Given this list of marker genes Erg, Neo1, Nedd4l, Ubr5, Gria3, Dlx1, Cul1, Tmem185a, Faxc, Dnmt3a, Homer1, Eif4enif1, Usp47, Slc24a2, Arhgef3, Nr3c1, Dab2ip, Ist1, Tnfsf11, Nfkbiz, Pes1, Magi2, Rab14, Txndc16, Daam1, Kpna4, Ap4m1 (adaptor-related protein complex AP-4, mu 1), Wtap, Gorasp2, Lmx1a, Usp31, Pdzrn4, Crispld1, Dcun1d1, Trp53inp1, Phf8, Kcnk1, Nxph2, Ctdspl2, Rc3h2, Ndrg4, Zic2, Ccdc82, Atl2, Tdo2, Cdh11, Vwc2l, Map4k3, Mllt10, Phactr1, Dynll1, Cntn1, Tanc2 (NCBI Gene Id 77097), Fmr1, Rora, Sdc3, Bfar, Rfx4, Slain2, Trhde, Slc35a3, Stag1, Ccdc83, Sp3, Brd10 (bromodomain containing 10), Slc20a2, Cyp4b1, Mbnl2, Msh3, Rreb1, Brca1, Sufu, Sema3e, Vav2, Arfgef1, Tab2, Col8a1, Dync2i1, Usp1, Nus1, Bcl6, Crebzf, App, Ppargc1a, Rin2, Fst, Lypla1, Tsc22d2, Gng5, Kmt2e, Esco2, Nfkbia, Nadk2, Vezf1, Satb1, Gtf2ird1, Ppp6r3, Bbc3, Kif21b, Abcc5, Sat1, Med13l, Vldlr, Nckap5, Gmps, Tlk1, Rab5c, Vps13d, Krtap13, Syt4, Osbpl1a, Fli1, Slc25a24, Tal1, B3gnt9, Rai1, Thap11, Psma5, Arhgef10l, Flrt3, Gas6, Xkrx, Tbc1d22b, Nek7, Scamp5, P2ry12, Dach1, Megf11, Hmgb2, Vangl2, Akap11, Tenm3, Npat, Hid1, Hmcn1, Rbm27 (RNA binding motif protein 27), Slc22a2, Senp7, Mrfap1, Shisa6, Dctn2, Elovl5, Dlc1, Lingo1, Susd6, Tbp, Hhip, Lhfpl3, Mbd5, Ccng2, Nid1, C1qbp, Areg, Fam228a, Myt1l, Arid4b, Stxbp5l, Slitrk6, Pom121, Anp32b, Lgr5, Zfp367, Naa15, Gon4l, Birc6 (baculoviral IAP repeat-containing 6), Mycbp2, Psmg2, Gtf2a1, Son, Iqub, Chrd, Rock1, Fezf2 (Fez family zinc finger 2), Klf15, Bcl11b, Atp13a3, Ebf3, Gabra5, Cxxc4, Itgb1, Kmt2d, Slc25a12, Arl8a, Mea1, Map3k8, Itga10, Zfp442, Arhgap44, Dennd4c, Myo1e, Gak, Zfp638, Fubp1, Hmgn1, Lrig1, Derl1, Snrpb2, Cited2, Ash1l, Cimip2a, Gramd4, Agps, Anks1, Adcy10, Memo1, Bclaf3, Jmjd1c, Rasgrp1, Tmem165, Rasl11b, Gdnf, Adgrl2, Rev3l, Dusp7, Hivep1, Atp5mk, Ints8, Kat6b (K(lysine) acetyltransferase 6B), Sgk1, Bap1, Eomes, Cep170b, Tacc1, Gorasp1, Tm9sf3, Anxa1, Dusp6, Dyrk4, Ralyl, Hoxa1, Slc6a17, Ggnbp2, Scn1a, M6pr, Zbtb33, here is a description of the gene set: species: Mus musculus Mouse Gene Set: LET_7A_2_3P Genes predicted to be targets of miRBase v22 microRNA mmu_let_7a_2_3p in miRDB v6.0 with MirTarget v4 prediction scores > 80 (high confidence targets). from publication Chen Y, Wang X (PMID 31504780)